The following is a description of a gene set: Mouse Gene Set: GOBP_PROLACTIN_SECRETION studied in species Mus musculus The regulated release of prolactin, a peptide hormone that stimulates lactation, from secretory granules in the anterior pituitary., and this is the list of marker genes: Anxa5, Abat, Anxa1, Ube2q1, Vip, Nmu, Tacr2, Egfr